The following is a description of a gene set: species: Homo sapiens Human Gene Set: GOMF_RIBONUCLEASE_P_ACTIVITY Catalysis of the endonucleolytic cleavage of RNA, removing 5' extra nucleotides from tRNA precursor., and this is the list of marker genes: POP1, POP7, RPP30, POP5, RPP14 (NCBI Gene Id 115127), RPP21, RPP25, RPP40, PRORP, POP4, RPPH1, RPP38